The following is a description of a gene set: Enables the transmembrane transfer of a monoatomic anion by a volume-sensitive channel. A volume-sensitive channel is a channel that responds to changes in the volume of a cell. studied in species Mus musculus Mouse Gene Set: GOMF_VOLUME_SENSITIVE_ANION_CHANNEL_ACTIVITY, and this is the list of marker genes: Lrrc8b, Ttyh3, Ttyh2, Ttyh1 (tweety family member 1), Clcn2, Lrrc8e, Clcn3, Lrrc8d, Lrrc8a, Lrrc8c, Shoc2